The following is a description of a gene set: Mouse Gene Set: GOMF_PHOSPHOLIPID_TRANSPORTER_ACTIVITY Enables the directed movement of phospholipids into, out of or within a cell, or between cells. Phospholipids are a class of lipids containing phosphoric acid as a mono- or diester. species: Mus musculus, and this is the list of marker genes: Serinc5, Ano7 (anoctamin 7), Ano5, Prelid2, Atp8a2, Ano10, Abcb1a, Atp11c, Plscr3, Ano1, Mfsd2a (MFSD2 lysolipid transporter A, lysophospholipid), Pitpna, Gltp, Xkr8, Plscr1l1, Pitpnc1, Gltpd2, Scp2, Serinc2, Ano2, Abcb4, Abca7, Atp8b1, Atp10b, Cptp, Mttp, Plscr1, Prelid1, Pitpnm3, Bltp1, Serinc3, Ano3, Atp11a, Plscr4, Plekha8, Tmem41b, Atg9a, Atp8b2, Prelid3a, Tmem30b, Ano6, Vmp1, Triap1, Atp8a1, Clptm1l, Xkr4, Pitpnb, C2cd2l, Atp10a, Pitpnm2, Pltp, Vdac2, Atg9b, Tmem30a, Atp8b3, Ano4, Pitpnm1, Ano8, Plscr2, Ano9, Osbpl2, Abca3, Atp8b5, Pctp, Abca4, Plscr5, Xkr9, Abcg1, Tnfaip8l3, Abca1, Prelid3b, Abcb1b (NCBI Gene Id 18669), Esyt1